The following is a description of a gene set: studied in species Homo sapiens Human Gene Set: GOMF_D_MANNOSE_BINDING Binding to mannose, a monosaccharide hexose, stereoisomeric with glucose, that occurs naturally only in polymerized forms called mannans., and this is the list of marker genes: DPM1, BSG, CLEC17A, CD209, CD207, CLEC4D, MBL2 (mannose binding lectin 2), CLEC4A, MRC1, LMAN1L, CLN5, LMAN2, ASGR1 (NCBI Gene Id 432), CLEC4M, IGF2R, LMAN2L, ASGR2, COLEC11, LMAN1, CLEC4G, CLEC6A, COLEC10 (collectin subfamily member 10), CLEC10A, ACR